Given this list of marker genes RNU6-775P, RPL21P30, ENSG00000287344, RNU6-612P (RNA, U6 small nuclear 612, pseudogene), PPP1R21, ENSG00000212175, PAPOLG, FTH1P6, ENSG00000228033, MTIF2, LINC01122, BCL11A, FBXO11, CCDC88A, ACYP2, MIR4431, MIR217, RNA5SP95, RNU4-49P, RNU4-51P, STON1, CFAP36, TPT1P11, CCDC85A, MSH6, RNU6-282P, RPL36AP15, ENSG00000230773, SPTBN1, RPS27A (ribosomal protein S27a), RTN4, EIF2S2P7, MIR217HG, LINC01795, GTF2A1L, LINC01813, ACTG1P22, EML6-AS1, RNU1-32P, KCNK12 (NCBI Gene Id 56660), LINC01867, EFEMP1, REL-DT, RNU6-433P, PPIAP63, MIR3682, SPTBN1-AS2, PNPT1, PPP4R3B, ENSG00000251942, RN7SL361P, NONOP2, MIR4432, RN7SKP208, RBISP5, CIMIP6, CRTC1P1, ERLEC1, FOXN2, FSHR (follicle stimulating hormone receptor), MIR548BA, RNU6-508P, STON1-GTF2A1L (NCBI Gene Id 286749), PPP4R3B-DT, TSPYL6, ELOBP3, VN1R18P, PPIAP62, RN7SL632P, RPL26P13, RPL7P13, CCDC12P1, RPL23AP32, EIF3FP3, RN7SKP224, RNU6-221P, NME2P2, RPS27AP7, RNU7-172P, ASB3, HMGB1P31, MTCO1P42, RNU6-439P, RNU6-997P, RNA5SP94, GPR75, ENSG00000233251, RNU6-634P, BTF3P5, GGCTP3 (GGCT pseudogene 3), ENSG00000233230, RPL21P33, NRXN1, RNU7-81P, LHCGR, FANCL, PRORSD1P, RPS12P3, MIR8485, MSH2-OT1, MIR216A, ATP1B3P1, CTBP2P5, NRXN1-DT, CDPF1P1, CLHC1, MIR4432HG, KNOP1P3, ZNF863P, SNORA75, VRK2, CHAC2, REL, SPTBN1-AS1, PPP1R21-DT, MIR216B, RNA5SP93, EML6, ENSG00000283058, PSME4, ENSG00000212168, IFITM3P9, CRYGGP, here is a description of the gene set: Human Gene Set: chr2p16 studied in species Homo sapiens